The following is a description of a gene set: species: Homo sapiens The chemical reactions and pathways resulting in the breakdown of misfolded or attenuated proteins. Human Gene Set: GOBP_PROTEIN_QUALITY_CONTROL_FOR_MISFOLDED_OR_INCOMPLETELY_SYNTHESIZED_PROTEINS, and this is the list of marker genes: PEX12, SAYSD1, CUL3 (cullin 3), AKIRIN2, OMA1, KLHL15, LONP1, ZSWIM8, ANKZF1, VCP, UBR4, CLPP, RNF126, IRGQ, LONRF2 (NCBI Gene Id 164832), AFG1L, TMEM126A, OXA1L, FBXL17, UBR5, ZYG11B, UBE2W, AFG3L2, ATXN3, YME1L1, PEX10, ZER1, ATXN3L, LONP2 (lon peptidase 2, peroxisomal), STUB1, HDAC6